The following is a description of a gene set: Human Gene Set: CTCTGGA_MIR520A_MIR525 species: Homo sapiens Genes having at least one occurence of the motif CTCTGGA in their 3' untranslated region. The motif represents putative target (that is, seed match) of human mature miRNAs hsa-miR-520a* and hsa-miR-525 (v7.1 miRBase)., and this is the list of marker genes: SEMA6D, SDC1, ZFP91, GTF2H1, PCDH19, THADA, CD28, YTHDF3, BCL11B, SMG1, GFRA2, RNF220, OTX2, TSPAN2, SPON1, UBE2C, ALG8, GNB2, RAPGEFL1, KRT40, DTNA, AMMECR1L, STX3, SLC11A2, TRIM33, CLCA3P, PPP6R3, FNBP1, ATRN, SLC26A6, PPP4C, SMOC1, ARID5A, MSH5, PAFAH1B1, WNT3, NUMA1, PPP3R1, PABPN1, IKZF4, YDJC, CGN, POGZ, FAM53C, SEC22A (NCBI Gene Id 26984), RAB11FIP1, THY1 (NCBI Gene Id 94105), TCF7L1, PUM2, LASP1, WNT7A, ARHGEF40, ACACA, RPUSD3, RAB5IF, UNG, NSD1, PRDM1, NCOR2 (nuclear receptor corepressor 2), PSMC3IP, SNX27, ERC2, MAPK1, PTEN, SP8, CAMK2G, ZNRF2, TSHZ1, RB1, ZNF655, ETV5, CLUH, SON, CDH20, HMGCLL1, ABCE1, NHS, RBM12, SPRY4, NAA15, ABL1, NOVA1, PHF13, MXD1, KRT34, GCLC, BCL7A, NAB1, ILRUN, SLPI, ORMDL3, SLC22A2, BSN, HCAR2 (NCBI Gene Id 338442), CLTB, NFE2L1, TNPO2, TPM3, CAMK2A, PIGF, NMT1, PART1, HOXD10, QKI, PPP1R9B, ATG16L1 (autophagy related 16 like 1), HMGA1, UBE2D2, HNF1B, USP5, METTL22, CDCP1, CADM2, TWIST1, ARF3, STAT6, DEDD, FZD9, KLF13, ABCG4, EIF4E2, SEH1L, COL4A3, OGT, PLXND1, PAK5, MROH7, ATF2, PPP4R3A, PGF, PBX3, TMCC2, MDGA2, NUP58, KMT2A, APLN (apelin), RSBN1, CDK2AP1, ATXN1 (NCBI Gene Id 7912), SMARCA1, STOML1, UBASH3B, PPP1R3F, CTDSPL, DHRS11, CAPN3, MTCL2, VPS54 (VPS54 subunit of GARP complex), DCHS1, ZC3H6, SATB2, SEPTIN7, MAPKAP1, MEIS2, PPP2R5E, FN1, CELF2, SINHCAF